The following is a description of a gene set: Binding to a RAGE receptor, the receptor for advanced glycation end-products. species: Mus musculus Mouse Gene Set: GOMF_RAGE_RECEPTOR_BINDING, and this is the list of marker genes: S100a7l2, Fpr3, Hmgb1, Fpr2, S100b, S100a13, Hmgb2, S100a7a, S100a4, App, Fpr1